The following is a description of a gene set: Human Gene Set: GOBP_CIRCULATORY_SYSTEM_PROCESS species: Homo sapiens An organ system process carried out by any of the organs or tissues of the circulatory system. The circulatory system is an organ system that moves extracellular fluids to and from tissue within a multicellular organism., and this is the list of marker genes: KCNMB2, GPR37L1, CAMK2D, CASR, KCND3, YAP1, GPER1, GLRX3, DMD, ATP1A2, TMEM65, CAV1, P2RX4, HTR7, PPP1R13L, CXCL12, HTR2A (NCBI Gene Id 3356), SLC2A10, CAV3, SLC22A5, KLK1, GJA1, SRC, NPR3, OCLN (NCBI Gene Id 4950), REN, CYBA, ID2, TH, DDAH1, ENPEP, PDE2A, WWTR1, HBB, SLC6A13, KCNE5, ATP2A1, CARTPT, LNPEP, F2RL1, GATA4, MIR26A1, ISL1, VEGFC, ABAT, BMPR2, SLC8A3, ACE, ATP8A1, ITGA1, MTOR, PKP2, GNAO1, ADD3, RNF207, HRH1, HSPB7, NDST2, MFSD2A, GJC1, HSD11B2, PIK3C2A, TTN, KLF2, TAC1 (NCBI Gene Id 6864), ADRB2, KCNMB4, ATP2B3, NEDD4L, NPPB, RYR2, CTNNBIP1, CACNA1C, SCPEP1, UTS2, GRK2, SLCO3A1, ACVRL1, KCNE1, SLC22A8, SCNN1G, POPDC2, BBS4 (NCBI Gene Id 585), ATG5, SLC2A3, TREX1, SLC4A8, MRGPRD, NAV2, SLC6A6, CD38, FXYD1 (FXYD domain containing ion transport regulator 1), CBS, MC3R, TACR3, NPR1, SLC16A7, SLC16A12, ATP6AP2, PPCS, SLC12A2, ERAP2 (NCBI Gene Id 87126), VEGFA, NOS2, MIR23A (NCBI Gene Id 407010), GJA5, ANGPT1, KL, GPX1, ADCY6, PRCP, MYH6, CPA3, ELN, FFAR3 (free fatty acid receptor 3), FLI1, MIR208A, GJC3, NOS1, MIR30E, RAC1, EXT2, C2CD4A, AGTR2, TAC4, GUCA2B, KCNJ5, P2RX1, TMEM38A, UMOD, SVEP1, CTNNA3, ABCC5, FGB, CRH, ADM5, ABCG2, SHOX2, COMT, RGS4, CYP4F12, KCNA5, SREBF1, BCR, YWHAE, AZU1, ITGB1, NPFF, JPH1, PTGS2, GCLM, SGCG, SCN1B, PTP4A3, PDGFB, PDE3A, SLC4A5, CPS1, BDKRB1, DSC2, KLK2 (kallikrein related peptidase 2), HEG1 (NCBI Gene Id 57493), TBXA2R, IRAG1, CACNA2D1, TMIGD3, MAS1, SLC9A1, ABCC4, MYL4, MTNR1B, RPS6KA2, GCLC, SLC22A1, FOXC2, SLC6A20, KNG1, SLC5A6, TMEM38B (transmembrane protein 38B), ADRA2C, LPA, SCN2A (sodium voltage-gated channel alpha subunit 2), MIR328, FKBP1A, FGF13, SLC15A2, ATP2A3, PCSK5, RARRES2 (retinoic acid receptor responder 2), TMEM161B, FGG, MEF2A, PPARG, AVPR1B, MIR133A1 (NCBI Gene Id 406922, microRNA 133a-1), CXADR, SCN4B, SLC16A1, ADRB3, FGF12, CALM1, ABCB1, SMTNL1, PLEC, TRPM4, PIK3CG, PLOD3, NHERF1, KCNK6, GNB3, DES (NCBI Gene Id 497658), NPR2, SLC1A1, SMAD7, SLC27A1, MANF, WNK4, SLC2A13, TTR, SLC6A1, HTR1B, ERAP1, ADRA1B, ADM, PTPN11, DLL1, SLC7A8, RAMP2, MYL3, SCN5A, SERPINF2, TRDN, BLOC1S6, SLC7A3, UTS2R, SCN7A, MDM2, MAP2K3, SLC28A2, P2RX2, SLC5A3, SLC4A3, ATP2B2, IER3, KCNIP2, SLC7A5, XCL2, FSHR, KCNN2, NOS3, GSK3A, SUMO1, CLDN5, SLC29A1, CTSG, TJP3, SLC22A3, P2RY2, SLC4A4, PER2, SCNN1A, SCN10A, SCN9A, FLVCR2, PRKACA (protein kinase cAMP-activated catalytic subunit alpha), ADAMTS16, SNX5, ATP1B1, OLR1, TCAP, ATP1B2, PREP, SLCO1C1, EDNRA, ADRA1D, TNNI2, NPY1R, SLC16A2, ACTA2, HRC, EMILIN2, PDE4B, ATP1A3, DMPK, CALCA, ZMPSTE24, DSP, QRFP (pyroglutamylated RFamide peptide), ATP2B1, CRP, SLC5A1, C3AR1, CMA1, AVPR2, IRX3, PTPN1, ABCA2, CHD7, ABCC2 (NCBI Gene Id 1244), ADRA2B, SLC38A1, SCN1A, KCNJ3, SLC27A4, MIR200C, MAP2K1, KCNE4, CSRP3, HSP90AA1, CALM3, DNM1L, GNA13, FGFBP3, LEPR, FYN, TRPC1, MYOF, EXT1, SLC6A4, MAP2K6, SPTBN4, AGTRAP, EMP2, AVPR1A, SOD2, CASQ2, SLC2A4, FLNA, TEK, MIR138-1, GUCY1B1, SRSF1, TJP1, RASL10B, VSTM4, TNNI3K, SH3GL2, TFRC, GPR4, BVES, SLC5A5, HTR1D, ARHGAP35, ABL1, ADRB1, ADM2, CD36, MIR21 (microRNA 21), SRI, TNNC1, HTR1A, ITGB1BP1, ADA, AVP, CXCL10, DRD2, TJP2, NOX4, PRKG1, TGFB2, CYP4F2, MIR92A1, JUP, EMILIN1, SLC6A17, MYLK2, SLC24A3, AKAP9 (NCBI Gene Id 10582), SUCNR1, ATP1A1 (NCBI Gene Id 476), MIR448, TRPV4, BMP6, ABCC1, EDN2, DLG1, POSTN, BRS3, P2RY1, FGA, ADRA1A, EDN3, ECE1, ZEB2, SNTA1, CALM2, F5, SLC19A1, TBX20, SGK1, SGCZ, CYP2J2, CDC42, CLIC2, MKKS, SCN4A, CDH5, TBXAS1, RENBP, SLC2A5, ENG, CACNA1G, ATP2A2, KCNE2, TPM1, PDE4D, ROCK2, TNNI1, PTGS1, SLC1A3, KCNE3, KCNIP1, CYP11B2 (cytochrome P450 family 11 subfamily B member 2), DSG2, ABCC3, FERMT2 (FERM domain containing kindlin 2), ACTC1, APELA, SLC1A5, PLVAP, SLC38A3, S100A1, HCN1, KCND2, NR2F2, STK39, AGT, ARHGAP42, KCNMA1, SMAD3, ADORA1, STUB1, CYP11B1, OR51E2, GUCY1A1, PECAM1, CELF2, SLC29A4, GAS6, IRX5, RGS2, ACE2, RHOA, TNF, MMP2, THRB, ADH5, LRP1, OXTR, RANGRF, SCNN1B, SCN11A, PTPRJ, CHRM2, APLN, ZDHHC21 (NCBI Gene Id 347748), KEL, SOD1, NTSR1, SLC7A2, SCN3A, PTPRO, NPPC, APOE, MIR1-1, JPH4, LRP3, OXT, SLC38A5, ATP1A4, MYH7B, GNA11, BIN1, ANK2, SCN3B, JPH2, SLC22A2, UCN, STAT1, NCALD, FKBP1B, SLC29A2, HRH2, CYB5R3, INS, ZC3H12A, CORIN, TACR2, GRIP2, FAAH, PLCB3, CHGA, DOCK4, NOS1AP (NCBI Gene Id 9722), SLC44A1, TBX18, FABP5, CACNA1D, GJD3, ZNHIT1, ADORA3, TACR1, MIR199A1, DRD1, ASPH, CACNB2, PLN, MIR17, GAB1, SPX, SERPING1, ANPEP, SCNN1D, INSR, GHRL, TRPA1, LEP, NKX2-5, TBX2, CTSZ, NTS, STRIT1, SLC2A1, C2CD4B, SLC7A1, CYP4A11, NOX1, BBS2 (Bardet-Biedl syndrome 2), SCN2B, PIK3CA, ADORA2A, GCGR, MECP2, KCNJ8, CORO2B, SLC1A2, MIR153-1, SCARB1, RAMP3, HEY2, RAP1GDS1, AGER, MIR27B, SMAD5, FOXC1, ROCK1, GSTM2, E2F4, KCNH6, SLC8A2, THRA, ABCC9, MYL2, GATA6, KAT2B, APP, ASIC2, TGFB1 (transforming growth factor beta 1), KCNQ1, TBX5, RNLS (renalase, FAD dependent amine oxidase), GCH1, NPY, EPO (NCBI Gene Id 82670), AGTR1, SCN8A, TAC3, SLC6A9, GLP1R, MYBPC3, PPARA, LRP2, GPD1L, FOXN4, ITGA9 (NCBI Gene Id 3680), MIR19A, ATP2B4, POMC, TBC1D8, VEGFB, LRP5, SLC38A2, CACNA1H, EHD3, ACSM3 (acyl-CoA synthetase medium chain family member 3), EDN1, SLCO2B1, BMP10, EDNRB, SLC8A1, MME, KCNJ12, TNNT2, ADIPOQ (adiponectin, C1Q and collagen domain containing), HCN3, WNK1, KCNK3, KCNH2, NPPA, MYL7, COMP, EPAS1, DRD3, HBEGF, MYH7, KLK3, DBH, NMU, BDKRB2, ADORA2B, F2R, ITGA4, GAA, SLIT2, TNNI3, JPH3, STC1, C10orf71, GSN, SLC13A3, YES1, DRD5, SLC23A2, ADCY10, CEACAM1, HTR2B (5-hydroxytryptamine receptor 2B), AKAP12, HCN4 (hyperpolarization activated cyclic nucleotide gated potassium channel 4), SLC1A4, ENSG00000274276, KCNJ2, HOPX, SGCD, ABCC8, AR, GSTO1, AMOT (angiomotin), PPARD, UTS2B, DOCK5, GNA12, COL1A2, NUP155, IMMP2L, ADRA2A